The following is a description of a gene set: Cell recognition between cells. May involve the formation of specialized cell junctions. studied in species Mus musculus Mouse Gene Set: GOBP_CELL_CELL_RECOGNITION, and this is the list of marker genes: Pmis2, H1f6, Nedd9, Pcdha7, Lypd4, Fetub, Spesp1, Spa17, Clgn, Sppl2c, Spaca4, Zp1, Havcr2 (hepatitis A virus cellular receptor 2), Adam5, Msn, Astl, Ephb1, Pcdhb6, Adam18, Izumo1, Crisp4, Ccr7, Dcst1, Hspa1b, Nck2, Cct6a, Folr2, Tmprss12, Dlg1, Zpbp, Atp8b3, Adam1a, Prss37, Spaca6, Dcst2, Adam1b, Zp3, St6galnac6, Tmem81, Cct5, Dock2, Cct4, Frey1, Clec2i, Prss55, Tex101, Ccl21a, Cct7, Cd81, B4galt1, Dock8, Spaca3, Ubap2l, Cct3, Hspa1l, Tnp2, Cct8, Adam3, Slxl1, Folr1, Cct2, Cd9, Aldoa, Cd6, Glipr1l1, Zp3r, Ccl19, Acr, Git1, Prf1, Smcp, Adam2, Adam32, Lgals3, Pcsk4, Vdac2, Zan, Zpbp2, Izumo1r, Garin3, Ovgp1, Cd2ap, Ly6k (NCBI Gene Id 76486), Tcp1, Arsa, Zp2